The following is a description of a gene set: species: Homo sapiens Catalysis of the transfer of an L-fucosyl group from GDP-beta-L-fucose to an acceptor molecule to form an alpha-(1->3) linkage. Human Gene Set: GOMF_ALPHA_1_3_FUCOSYLTRANSFERASE_ACTIVITY, and this is the list of marker genes: FUT7 (NCBI Gene Id 2529), FUT4, FUT5, FUT9, FUT10, FUT11, FUT3, FUT6